The following is a description of a gene set: Catalysis of the reaction: a very-long-chain acyl-CoA + H+ + malonyl-CoA = a very-long-chain 3-oxoacyl-CoA + CO2 + CoA. This reaction is the first (condensation) step of the four-step fatty acid elongation cycle in the endoplasmic reticulum that extends fatty acids of C-16 or longer with an additional 2-C unit. studied in species Homo sapiens Human Gene Set: GOMF_FATTY_ACID_ELONGASE_ACTIVITY, and this is the list of marker genes: ELOVL7, ELOVL1, ELOVL3, ELOVL4, ELOVL6, ELOVL5, ELOVL2